The following is a description of a gene set: studied in species Homo sapiens Any process that modulates the frequency, rate or extent of cell fate commitment. Cell fate commitment is the commitment of cells to specific cell fates and their capacity to differentiate into particular kinds of cells. Positional information is established through protein signals that emanate from a localized source within a cell (the initial one-cell zygote) or within a developmental field. Human Gene Set: GOBP_REGULATION_OF_CELL_FATE_COMMITMENT, and this is the list of marker genes: CHD4, PAX7, MBD3, BMPR1A, MIR133A1, GDF3, DKK1, HDAC1, NKX6-2, BRD4 (NCBI Gene Id 90616), TBX21, IL12RB1, MTA2, RBBP7, CHD3, LMO4, JAK3, BMP4, SPDEF, SOSTDC1, GATAD2A, TNFSF18, CD69, MIR1-1, OPA1, RBBP4, SFRP2, FGF2, ESRP1, HDAC2, MIR208A, MTA3, IL23A, FZD7, SOX17, HES1, LOXL3, STAT5A, BRD2, IL12B, IL23R, MESP1, FGFR1, LGALS1, MIR206, WNT3A, GATAD2B, MTA1, EP300